Given this list of marker genes Hgf (NCBI Gene Id 15234), Gga3, Rab4a, Grb2, Gab1, Crk, Arf6, here is a description of the gene set: electronically inferred by orthology from the curated human pathway part of: Signaling by MET Reactome Pathway: MET receptor recycling species: Mus musculus This event has been computationally inferred from an event that has been demonstrated in another species.<p>The inference is based on the homology mapping from PANTHER. Briefly, reactions for which all involved PhysicalEntities (in input, output and catalyst) have a mapped orthologue/paralogue (for complexes at least 75% of components must have a mapping) are inferred to the other species.